Given this list of marker genes DPYD, TYW1, XDH, RPS3, METTL17 (methyltransferase like 17), ACO2, CDK5RAP1, KIF4A, DPH1, AIFM3, ABCE1 (NCBI Gene Id 6059), ISCA1, CDKAL1, NUBP1, FECH, NUBPL, UQCRFS1, PPAT, BOLA2, FXN, FDX1, UQCRFS1P1, NDUFS2, POLR3F, NFS1, KIF4B, GLRX2, RTEL1, DDX11L8, IREB2, GLRX3, ISCA2, FDX2, CISD2, NFU1, POLE, LIAS, ERCC2, CIAPIN1, CISD3, ISCU, SLC25A39, NTHL1, RSAD1, MOCS1, TYW1B, DDX11, GLRX5, ABAT, PRIM2, MUTYH, AOX1, KIAA0753 (KIAA0753), NDUFS7, RSAD2, DPH2, REV3L, ACO1, EXO5, CISD1, NUBP2, NDUFV1, NDUFS1, DNA2, DDX12P, SDHB, BOLA2B, POLD1, NDUFS8, FBXL5, ETFDH, CIAO3, NDUFV2, BRIP1, RFESD, ELP3, GSTP1, here is a description of the gene set: Binding to a cluster of atoms including both metal ions and nonmetal atoms, usually sulfur and oxygen. Examples include iron-sulfur clusters and nickel-iron-sulfur clusters. Human Gene Set: GOMF_METAL_CLUSTER_BINDING studied in species Homo sapiens